The following is a description of a gene set: Any process that decreases the rate, frequency or extent of platelet aggregation. Platelet aggregation is the adhesion of one platelet to one or more other platelets via adhesion molecules. species: Mus musculus Mouse Gene Set: GOBP_NEGATIVE_REGULATION_OF_PLATELET_AGGREGATION, and this is the list of marker genes: Serpine2, Sh2b3, Ceacam1, Cd9, Prkcd, Prkg1, Adamts18, Ubash3b, Tmx1, C1qtnf1, Alox12